Given this list of marker genes HES1, SFTPD, TGFB2, MAPK12, IL10, CD34, DOCK2, SOCS5, MAPK14, BHLHA15, CXCL8, PF4, MAPK7, EREG, here is a description of the gene set: Genes positively correlated with memory B cell response at 28d in peripheral blood mononuclear cell in seniors (50-74) after exposure to Fluarix, time point 28D. Comment: selected pathways: leukocyte migration, MAP kinase activity, cytokine signaling, diabetes of the young Human Gene Set: HARALAMBIEVA_PBMC_FLUARIX_AGE_50_74YO_CORR_WITH_28D_MEM_B_CELL_RESPONSE_AT_28DY_LEUK_MIGR_MAPK_ACT_CYTOK_SIG_DIAB_OF_THE_YNG_POSITIVE species: Homo sapiens from publication Haralambieva IH, Ovsyannikova IG, Kennedy RB, Zimmermann MT, Grill DE, Oberg AL, Poland GA (PMID 27317456) BACKGROUND: Studies suggest that the recall-based humoral immune responses to influenza A/H1N1 originates from activated memory B cells. The aim of this study was to identify baseline, early and late blood transcriptional signatures (in peripheral blood mononuclear cells/PBMCs) associated with memory B cell response following influenza vaccination. METHODS: We used pre- and post-vaccination mRNA-Seq transcriptional profiling on samples from 159 subjects (50-74years old) following receipt of seasonal trivalent influenza vaccine containing the A/California/7/2009/H1N1-like virus, and penalized regression modeling to identify associations with influenza A/H1N1-specific memory B cell ELISPOT response after vaccination. RESULTS: Genesets and genes (p-value range 7.92E(-08) to 0.00018, q-value range 0.00019-0.039) demonstrating significant associations (of gene expression levels) with memory B cell response suggest the importance of metabolic (cholesterol and lipid metabolism-related), cell migration/adhesion, MAP kinase, NF-kB cell signaling (chemokine/cytokine signaling) and transcriptional regulation gene signatures in the development of memory B cell response after influenza vaccination. CONCLUSION: Through an unbiased transcriptome-wide profiling approach, our study identified signatures of memory B cell response following influenza vaccination, highlighting the underappreciated role of metabolic changes (among the other immune function-related events) in the regulation of influenza vaccine-induced immune memory.